The following is a description of a gene set: Human Gene Set: GOBP_REGULATION_OF_VIRAL_LIFE_CYCLE species: Homo sapiens Any process that modulates the frequency, rate or extent of viral life cycle., and this is the list of marker genes: HMGB1, INPP5K, BSG, BST2, APOBEC3D, GBP7, TRIM28, STAU1, ZNFX1, HS3ST5, CD28, AXL, NOTCH1, KPNA6, TMPRSS2, SMPD1, FMR1, LGALS1, TRIM5, LGALS9, VPS4A, EIF2AK2, ADAR, TRIM62, CSNK2B, ISG15, APOBEC3B, PROX1, CXCL8, SLPI, BCL2, PKN2, CD4 (CD4 molecule), N4BP1, IFIT1, TMPRSS4, P4HB, TRIM25, TRIM15, RSAD2, APOBEC3F, PABPC1, HMGA2, IFNB1, PPIE, VPS37B, CLEC4G, MAVS, CH25H, TNF, SRPK1, KPNA2, TRIM38, CNOT7, DDB1, FURIN (NCBI Gene Id 5123), CD74, DDX5, DDX3X, FAM111A, RNASEL, TSG101, BANF1, APOBEC3G (NCBI Gene Id 80065), IFITM3, HLA-DRB1, HACD3, OAS2, IL32, LAMP3, CCL5, NECTIN2, IFNL3, TRIM21, ILF3, TARBP2, CD209, TYRO3, APOBEC3H, OAS3, NR5A2, IFI16, IFITM2, ADARB1, PPIA, BTBD17, IFIH1, RAD23A, OASL, PPID (NCBI Gene Id 5481), FKBP6, ZC3HAV1, TRIM6, ARK2N, LARP1, IFIT5, PPIH, PLSCR1, OAS1, APOBEC3A, MX1, SRPK2, TOP2B, PDE12, AICDA, TRIM11, APOBEC3C, ISG20, SHFL, IFITM1 (NCBI Gene Id 8519), TMEM39A, TNIP1, TOP2A, LTF, VAPB